Given this list of marker genes IL9, TNF, CCL5, IL3, EDN1, IL2, KAT5, CSF2, VCAM1, IL12A, IL18, IL5, IL11, IL4, CXCL8, KITLG, IL6, NOS2, CCL11, IL13, CCL13, here is a description of the gene set: NF-kB-driven pro-inflammatory genes that are negatively regulated by glucocorticoids. A variety of studies have shown that some activated nuclear receptors (NRs), especially the glucorticoid receptor, the estrogen receptor and peroxisome proliferator-activated receptor, can inhibit the activity of the transcription factor nuclear factor kappaB (NF-kappaB), which plays a key role in the control of genes involved in inflammation, cell proliferation and apoptosis. This review describes the molecular mechanisms of cross-talk between NRs and NF-kappaB and the biological relevance of this cross-talk. The importance and mechanistic aspects of selective NR modulation are discussed. Also included are future research prospects, which will lead to a new era in the field of NR research with the aim of specifically inhibiting NF-kappaB-driven gene expression for anti-inflammatory, anti-tumor and immune-modulatory purposes. Human Gene Set: DEBOSSCHER_NFKB_TARGETS_REPRESSED_BY_GLUCOCORTICOIDS from publication De Bosscher K, Vanden Berghe W, Haegeman G (PMID 17072333) studied in species Homo sapiens